Given this list of marker genes Mttp, Abcb1a, Gltp, Vapa, Abca12, Sgpp1, Abcb1b (NCBI Gene Id 18669), Plekha8, Abca13, Cert1, Gltpd2, Cptp, Psap, Pltp, Osbp, Abca2, here is a description of the gene set: The directed movement of ceramides into, out of or within a cell, or between cells, by means of some agent such as a transporter or pore. Ceramides are a class of lipid composed of sphingosine linked to a fatty acid. Mouse Gene Set: GOBP_CERAMIDE_TRANSPORT species: Mus musculus